Given this list of marker genes Ackr3, Slc32a1, Six3, Lhx6 (LIM homeobox protein 6), Abat, Nrxn3, Npy, Gria4, Nxph1, Sst, Dlx1, Pvalb, Erbb4, Cxcr4, Calb1, Dlx5, Dlx6os1, Slc6a1, Gria1 (glutamate receptor, ionotropic, AMPA1 (alpha 1)), Dlx6 (NCBI Gene Id 13396), Gad2, Grip1, Gad1 (glutamate decarboxylase 1), Dpp10, Dlx2, here is a description of the gene set: Genes selectively expressed by interneuron precursors in embryonic day 14.5 mouse cortex. Mouse Gene Set: HEVNER_CORTEX_INTERNEURON_PRECURSOR_CELLS from publication Bedogni F, Hevner RF (PMID 34321999) studied in species Mus musculus